Given this list of marker genes Cebpz, Nfyc, Atf2, Ing2, Nfya, Nfyb, here is a description of the gene set: Mouse Gene Set: GOCC_CCAAT_BINDING_FACTOR_COMPLEX A heteromeric transcription factor complex that binds to the CCAAT-box upstream of promoters; functions as both an activator and a repressor, depending on its interacting cofactors. Typically trimeric consisting of NFYA, NFYB and NFYC subunits. In Saccharomyces, it activates the transcription of genes in response to growth in a nonfermentable carbon source and consists of four known subunits: HAP2, HAP3, HAP4 and HAP5. species: Mus musculus